Given this list of marker genes Gpnmb, Hbegf, Egfr, Lrrk2, Hif1a, Ptk6, here is a description of the gene set: Mouse Gene Set: REACTOME_PTK6_PROMOTES_HIF1A_STABILIZATION studied in species Mus musculus PTK6 promotes HIF1A stabilization